The following is a description of a gene set: species: Homo sapiens Human Gene Set: GSE1740_UNSTIM_VS_IFNA_STIMULATED_MCSF_DERIVED_MACROPHAGE_UP Type I IFN-inducible gene expression in human blood monocytes primed with Type II IFN. Genes up-regulated in monocyte-derived macrophages: untreated versus stimulated by interferon alpha. from publication Tassiulas I, Hu X, Ho H, Kashyap Y, Paik P, Hu Y, Lowell CA, Ivashkiv LB (PMID 15467722), and this is the list of marker genes: MCTP2, ZNF76, PPM1E, ZNF705G, GCSIR, ENPP5, MYOT, OR10D3, IGFL1, CALCB, STEAP2, GPR150, OPLAH, HDAC4, SIM1, GPRASP3, DCAF11, CFAP184, ULBP2, ASPRV1, TULP4, GET4, DCAF4L1, GABRB3, KCTD7, ARL5C, PHRF1, C6orf141, CDH9, KRTAP4-7, CHPF2, RAB4B, NEK8, SLC7A13, NOP56, LOXL1-AS1, MAP3K11, GCHFR, BMS1P1, ENSG00000291065, ZNF197, ZNF766, LINC01278, NRG4, DEFB126, C1orf220, LYZL4, TCP10L, PMS2P5, SYCP2, CAPN3, ZDHHC12, OR51B6, LINC00964, KRTAP19-1, NBAS, SLC46A3, SLC35F2, CBLN1, RBM28, PPRC1, LRRC73, AP1AR, MKRN2, EPB42, NEUROD2, KRT1, ESAM, TTTY2, SLC26A4-AS1, CNBD1, KCNV1, ZNF225-AS1, GCDH, SORBS3, ZNF324, PIP5K1B, C2orf69, ZNF467, KEAP1, SLC35F3, CA14, LMNA, ADGRF3, XPA, RBFA (ribosome binding factor A), PNMA8A, PCDHB2, ZSWIM8, XXYLT1, ZNF665, CFAP96, FAM43B, LINC01539, HSF5, FBLN1, RPAP1, ASPM, PCGF1, TAF4B, PGGT1B, SCYL1, TUBGCP4, OR6A2, EXOC6B, GPR161, PLAAT3, KAAG1, ZNRF2P1, ANKRD54, RANBP6, GDF9, FAM169BP, SIRT4, CRYL1 (crystallin lambda 1), PPY, CD3E, ZNHIT6, MAGEC2, TCL1B, LINC03006, GASK1B, FBXO2, ZNF804B, NKAIN1, PCIF1, CELF5, AMT, TMEM125, IL20RB, DYNC2I2, LINC00339, CEP57L1, CYP4A22, ANKRD52 (ankyrin repeat domain 52), ENSG00000275465, ZBED1, PDCL, TMEM253, ANXA10, RBM24, COMMD1, PLEKHO1, E2F7, DTYMK, FBXO42, ZNF253, PRTFDC1, VPS18, L3MBTL3, TMEM26, KATNAL2, RSPO2, TMEM147, HSF2BP, SLC38A11, DMRTB1, NRXN3, ADGRA3, PLAC4, PTPRF, ABRA, ZNF669, EDA2R, RHCE, HMX2, PHF20, GABRA2, CENPL, CDH5, CYYR1, PTPRK, MROH8, PCDHGB5, RPP14, IDH3G, FSTL5, RABGEF1P1, STAP1, ACTR5 (NCBI Gene Id 93972), BTRC, VPS9D1, P2RY11, GTF2H5, HOXD13 (homeobox D13)